The following is a description of a gene set: Mouse Gene Set: GOBP_REGULATION_OF_DOPAMINERGIC_NEURON_DIFFERENTIATION studied in species Mus musculus Any process that modulates the frequency, rate or extent of dopaminergic neuron differentiation., and this is the list of marker genes: Foxa1, Ferd3l, Shh, Dkk1, Id2, Tiam1, Foxa2, Gsk3b, Sfrp1, Sfrp2, Wnt3a